Given this list of marker genes AGO3, NPAS4, miR-224, NR3C1, SRF, TNRC6C, TNRC6A, TNRC6B, REST, KCNIP3, AGO2, MOV10, AGO4, AGO1 (NCBI Gene Id 26523), here is a description of the gene set: Reactome Pathway: Regulation of NPAS4 gene expression NPAS4 is predominantly expressed in neuronal cells. In neurons, expression of NPAS4 is regulated by Ca2+, which ties NPAS4 level to neuronal activity.<br><br>NPAS4 expression is regulated by signaling pathways activated downstream of the N-methyl-D-aspartate (NMDA) receptor and L-type Ca2+ channel.<br><br>In vivo, NPAS4 expression is activated by visual stimulation, contextual learning, as well as pharmacologically induced generalized seizure. Chronic stress induces downregulation of NPAS4 gene expression in the hippocampus, so does social isolation. Adult female mice who were exposed to early maternal separation (early life stress) show upregulation of NPAS4 in the prefrontal cortex later in life. NPAS4 is thought to have a neuroprotective effect and is downregulated during neurodegeneration. NPAS4 level is reduced in the hippocampus of aged, memory-impaired mice. Studies in mice indicate that NPAS4 affects synaptic connections in excitatory and inhibitory neurons, neural circuit plasticity, and memory formation. NPAS4 may be involved in the functioning of the circadian system.<br><br>Npas4 mRNA levels are downregulated upon infection with Zika virus through an unknown mechanism.<br><br>Besides neuronal cells, NPAS4 is also expressed in pancreatic beta cells, where its levels are regulated by intracellular calcium, as in the nervous system. part of: Transcriptional Regulation by NPAS4 studied in species Homo sapiens